Given this list of marker genes Nudt15 (NCBI Gene Id 214254), Pnp, Dguok, Ada, Guk1, Ak2, Oga, Adk, Ak3, Nudt16, Samhd1, here is a description of the gene set: species: Mus musculus The chemical reactions and pathways involving purine deoxyribonucleoside triphosphate, a compound consisting of a purine base linked to a deoxyribose sugar esterified with triphosphate on the sugar. Mouse Gene Set: GOBP_PURINE_DEOXYRIBONUCLEOSIDE_TRIPHOSPHATE_METABOLIC_PROCESS